The following is a description of a gene set: species: Homo sapiens Human Gene Set: SRY_01 Genes having at least one occurrence of the motif AAACWAM in the regions spanning 4 kb centered on their transcription starting sites. This matches the SRY transcription factor binding site V$SRY_01 (v7.4 TRANSFAC)., and this is the list of marker genes: GFRA1, SORL1, ELAVL4, LMO3, MAML2, PIK3C2A, HMGN2, ZNF436-AS1, PCF11, CDKN2C (cyclin dependent kinase inhibitor 2C), SH3GLB1, SLC26A9, PIK3CD, MTX1, HOXC6, CLSTN1, SEMA4G, NOX4, SESN2, TCP11L2, PLPP3, KCNA1, HABP2, GRIN2B, OPCML, CKAP4, GNL2, ZNF644, AKR1A1, CLEC1B, ASCL2, DCHS1, SLC38A4, ANGEL2, ATF7, MPZL2, SRGN, VDR, DDX6, CSDE1, LRP5, ING4, CCDC89, NBL1, PLEKHS1, SH3D21 (SH3 domain containing 21), SLC25A34, BARHL2, SZT2, CSAD, S1PR1, TCF7L2, ATP2A2 (ATPase sarcoplasmic/endoplasmic reticulum Ca2+ transporting 2), DFFB, HTR3B, TBX5, RFX4, TM9SF3, RNF220, C1orf21, NMNAT2, LDB1, PDE3B, TMEM50A, EFNA4, PRMT3, HOXC4, CA14, RBM8A, TEAD4, BEND5, ATXN7L2, B3GALT2, FAM53B, GAB2, INSRR, OTUD7B, SORT1, TNKS2, GABARAPL1, ZNF362, JAML, ELF5, MACO1, EHF, RBM4, LYST, PNPLA2, CADM1, MXRA8, PRMT6, NOS1AP, ATF7IP, SELENBP1, NAV3, C1orf43, NFIA, NCAM1, PLEKHA5, PAMR1, HECTD2, RAB6A, MGAT4C, SORBS1, DAB1, METTL18, H3-3A, LEMD1, LALBA, DDIT4 (NCBI Gene Id 54541), CTTNBP2NL, EIF4G2, PHF21A, ZBED5, CREBL2, EMX2, MPZ, EFNA1, CRTC2, STMN1, THBS3, EGR2, CHTOP, ESRRG, LAMC2 (laminin subunit gamma 2), WBP1L, TEAD1, MAGI3, MARCHF5, LRRN4CL (NCBI Gene Id 221091), EMSY, SOX5, CLC, YPEL4, MAB21L3, SP1, PLXDC2, ZNF436, SKIDA1, RALGPS2 (NCBI Gene Id 55103), C12orf50, RNF214, GLB1L3, PLXNA2, LRP6, YBX1, PDCD4, NABP2, PAX6, TPH2, PNLIPRP2, MXI1, CPEB3, SOX6, RBP3 (retinol binding protein 3), FIRRM, DEDD, PDE6C, LHX9, AKR1E2, MSRB3, CRY2, ZBTB18, CACNA1E, FCHSD2, CLEC4D, MORN4, DLG2, MED8, PRRX1, CDK17, FAM76A, ENTPD1, LBX1, ZBTB37 (NCBI Gene Id 84614), USP44, FKBP2, CTSK, TSEN15, TDRD5, PALMD, HOXC8, HLX, ANAPC15, DEPDC7, ABLIM1, SPON1, GGPS1, ST6GALNAC5, TRIM8, DUSP6, PRKAG1, ARID4B, CDKN1C, CTNNA3, ANKS1B, ST8SIA1, KCNQ1DN, RASSF8, NECTIN1 (NCBI Gene Id 84853), RPUSD4, NRAS, SPINDOC, LINC01465 (NCBI Gene Id 283416), ATP1A4, F11R, DHRS3, ANK3 (ankyrin 3), MARCKSL1 (MARCKS like 1), SGIP1, FAM107B, KIRREL1, TAL1, TOR1AIP2, BAMBI, JMJD1C, NTS, BCL9, LGI1, DPYSL4, CYP26A1, GRK5 (G protein-coupled receptor kinase 5), PDZRN4, KMT2A, USF1, DNAJC22, CCN1, ZZZ3